Given this list of marker genes Psmb6, Psmc3, Nfkb1, Bcl10, Nfatc1, Src (NCBI Gene Id 99351), Map3k7, Card9, Psmd2, Psmd13 (proteasome (prosome, macropain) 26S subunit, non-ATPase, 13), Psmb5, Ube2m, Psmc6, Nfatc3, Uba52, Ube2d1, Plcg2, Uba52rt, Ppp3ca, Ppp3cb, Psmd1, Psmb4, Psmb2, Card11, Ikbkb, Psmc1, Uba3, Skp1, Psmc2 (proteasome (prosome, macropain) 26S subunit, ATPase 2), Psma2, Nfkbia, Psmc4, Psma1, Psma7, Tab1, Ppp3r1, Pycard, Psma6, Cul1, Calm3, Ube2d2a, Ube2v1, Psma4, Tab2, Psmd12 (proteasome (prosome, macropain) 26S subunit, non-ATPase, 12), Psmd3, Psmd6, Ube2n, Psmd7, Cdc34, Nfatc2, Rps27a (NCBI Gene Id 78294), Calm1, Traf6, Psma3, Calm2 (NCBI Gene Id 75700), Psmb3, Psmb1, Fbxw11, Psmc5, Pdpk1, Psmd14, Tab3, Map3k14 (mitogen-activated protein kinase kinase kinase 14), Relb, Ikbkg, Rela, Ubc (ubiquitin C), Prkcd, Il1b, Psmd8, Ubb, Chuk, Malt1, Psmd11, Psmb7, Psma5, Casp8, Nfkb2, Adrm1, here is a description of the gene set: Mouse Gene Set: REACTOME_CLEC7A_DECTIN_1_SIGNALING studied in species Mus musculus CLEC7A (Dectin-1) signaling